Given this list of marker genes ZNF589, USP31, SOS2, ZNF426, NLK, HAPLN1, CCDC88C, CELSR1, ANKRD23, BEND3, PLXND1, CLIP1, TPR, KL (NCBI Gene Id 9365), PDPN, LIN7C, CDCA7L, TAB3, CCNJ, EIF5B, MGAT4B, TUBG1, BTRC, MGAT3, ABHD17C, RAD23B, IL36B, ARHGAP21, RALGAPA1, KLHL29, NAA40, ADD3, SLC24A3 (NCBI Gene Id 96617), PPFIBP1, TXNL1 (thioredoxin like 1), MAP3K11, AGAP1, ACVR2B, HIF1A (hypoxia inducible factor 1 subunit alpha), ZBTB20, PODXL, GSK3B, ZNF189, SHOC2, WDR76, KPNA4, TGFB2, ZNF563, ZNF479 (zinc finger protein 479), TAFA2, MARCHF8, SLF2, BLTP1, IPO8, ATG14, SORCS3, P3H2, RNF38, CRYBG3, SERPINE1, TAF9B, ZNF704, PAX3, AP1G1, RCSD1, ZNF516, HSPA5 (heat shock protein family A (Hsp70) member 5), UBAP1, RASSF2, GPRC5A (G protein-coupled receptor class C group 5 member A), FER, FZD4, MYRF, MARCHF7 (NCBI Gene Id 64844), ATP13A2, NCSTN, SIRT1, ARRB2, HMCN1, PLXNA2, SMARCD1, FLRT3, RFX3, PI4KA, TMEM245, MAB21L1, GPR89A, ZNF468, KDM3B, ETS1, WDTC1, CYP51A1, ZFP90, CACNB2, ZNF773, GCNT2, ASRGL1, DDR1, ITGA3, FAM222B, AUTS2, GPR63 (G protein-coupled receptor 63), RNF11, ECE1, ZNF776, PAN3, TSPAN6, ZNF559, ZNF195, ZNF440, NTNG1, HSPA12A, FBXO4, AFTPH, M6PR, RASSF3, ZNF584, MINDY3, SUN1, CCDC43, ZNF329, NUDT5, PAXBP1, PLEKHF2, POU3F2, DENND6A, RBM47, HYCC2, CREBRF, WAPL, CCDC120, SACS, ZNF439, PDE4D, CEP350, LXN, MICAL3, ZNF763, NPY2R, RGMA, TMEM220, CLCN3, ITGA8, ZNF418, RBPMS, CLEC2D (C-type lectin domain family 2 member D), CACUL1, ZNF559-ZNF177, PIK3CD, ABCA1, SULF1, NFIL3, GNG5, VPS26A, NINL, ZFAND4, ATXN7, CECR2, ZNF579, CELF2, ARF6 (NCBI Gene Id 63379), ZNF544, ZFYVE27, GPR89B, TST, GIT1, ARHGAP12, ANK3, NPAS2, AKAP1, USPL1, RAB7A, INO80D, PPARGC1A, CSDC2, SLC25A23, BCAM, NSG1, FZD6, BICC1, CCNL1, here is a description of the gene set: species: Homo sapiens Genes predicted to be targets of miRBase v22 microRNA hsa-miR-199a-5p in miRDB v6.0 with MirTarget v4 prediction scores > 80 (high confidence targets). Human Gene Set: MIR199A_5P from publication Chen Y, Wang X (PMID 31504780)